Given this list of marker genes Lhx3, Nkx2-2, Insm1, Hes1, Jag1, Bmp2, Gata2, Pou3f2, Rfx6, Notch1 (NCBI Gene Id 68125), Ascl1 (achaete-scute family bHLH transcription factor 1), Wnt11, Bccip, Wnt4, Otp, Nkx6-3, Fgf8, Onecut1, Fgf2, here is a description of the gene set: Mouse Gene Set: GOBP_NEUROENDOCRINE_CELL_DIFFERENTIATION The process in which a relatively unspecialized cell acquires specialized structural and/or functional features of a neuroendocrine cell. A neuroendocrine cell is a cell that receives input form a neuron which controls the secretion of an endocrine substance. studied in species Mus musculus